Given this list of marker genes NNT, PRKAR1A, MC2R, TXNRD2, POR, MRAP, STAR, here is a description of the gene set: species: Homo sapiens Decreased circulating dehydroepiandrosterone concentration Human Gene Set: HP_DECREASED_CIRCULATING_DEHYDROEPIANDROSTERONE_CONCENTRATION